Given this list of marker genes PCNT, SREBF1 (NCBI Gene Id 6720), GBP1, FBLN2, ARMH1, LIMS2, CCR7, CPNE2, RCAN3, LINC01550, S100B, A1BG, LRRN3, SERINC5, PRKAR1B, FAM117B, DBN1, TRABD2A, MAL, CD248, LDLRAP1, SIT1, SGK1, STMN3, PAK1, NPDC1, PECAM1, JUP, SPINT2, IGFBP2, NT5E, TMEM204, CD5, TOB1, CHI3L2, SIRPG, PASK, BACH2, MEOX1, NELL2, LINC02446, THEMIS, CD79A, CLEC11A, SERPINF1, ACTN1, CD8B, LYPD3, YBX3, here is a description of the gene set: species: Homo sapiens Human Gene Set: HE_LIM_SUN_FETAL_LUNG_C4_CD8_T_CELL CD8 T from publication He P, Lim K, Sun D, Pett JP, Jeng Q, Polanski K, Dong Z, Bolt L, Richardson L, Mamanova L, Dabrowska M, Wilbrey-Clark A, Madissoon E, Tuong ZK, Dann E, Suo C, Goh I, Yoshida M, Nikolić MZ, Janes SM, He X, Barker RA, Teichmann SA, Marioni JC, Meyer KB, Rawlins EL (PMID 36493756)